Given this list of marker genes Nrdc, Aph1b, Snx33, P2rx7, Adra2a, Psen2, Ptpn3, Prtn3 (NCBI Gene Id 19152), Sppl2a (NCBI Gene Id 66552), App, Tspan17, Adam10, Cwh43, Snx9, Rbmx, Aph1c, Gpld1, Tspan5, Pacsin3, Sppl3, Tspan15, Bace1, Psen1, Timp2, Timp4, Sppl2b, Tnfrsf1b, Sh3d19, Adam9, Adam17, Apoe, Ncstn, Myh9, Prkcq, Il10, Dag1, Ifng, Mmp7, Bace2, Tnf, Timp1, Adam19, Erap1, Psenen, Rbmxl1, Lrig2, Adam8, Rgma, Il1b, Sppl2c, Aph1a, Timp3, here is a description of the gene set: Mouse Gene Set: GOBP_MEMBRANE_PROTEIN_ECTODOMAIN_PROTEOLYSIS species: Mus musculus The proteolytic cleavage of transmembrane proteins and release of their ectodomain (extracellular domain).